Given this list of marker genes Usp25, Spata13, Jmjd1c, Gpd2, L3mbtl3, Crim1, Cbx5, Aasdhppt, Cyfip1, Gk (NCBI Gene Id 319419), Pank3, Atp7a, Angpt2, Mllt3, Lmbrd2, Pcsk5, Ube2d3, Zfp626, Zfp81, Elapor2 (endosome-lysosome associated apoptosis and autophagy regulator family member 2), Xcr1, C330018D20Rik, Gucy2f, Smarcd1, Washc5, Aqp4, Sh3gl3, Morf4l1, Cse1l, Ak2, Lypla1, Slc41a1, 1700129C05Rik, Pigo, Crmp1, Ski, Srgap1, Pcdhb16, Olr1, Ipmk, Nr2f2, Mmp13, Arl14epl, Il7, Prex2, B230219D22Rik, Ift70a1, Peli1, Lmo2, Spopl, Ino80, Slc25a30, Gypa, Desi2, Gadd45a (NCBI Gene Id 13197), Mbnl2, Cts7, Rbm20, Agtr1b, Ffar4, Zfp746, Sun1, Prpf4b, Trmt2b, Fam118b, Tmem263, Dclk2, Lnx2, Mtx3, Hsp90b1, Crybg3, Sdk1, Frat1, Pakap, Acp3, Rictor, Kctd4, Bicd1, Pcdh10, Nr2c2, Ccdc89, Arhgef28, Ankrd17, Klhl7, Eloc, Cenpc1, Ptpra, Scp2, Nap1l4, Rad51, Phlpp1, D5Ertd579e, Nmur2, Atad2, Phip, Zfp91, Rev3l, Gabra2, Dnajc27, Frem2, Rora, Eea1, Cpne8, Cpn2, Cep72, St8sia3, Ddias, Lats2 (NCBI Gene Id 50523), Abcb1a, Tm9sf3, Dbnl, Ifi213, Far1, Slc8a1, Camsap3, Zdhhc17, Doc2a, here is a description of the gene set: species: Mus musculus Genes predicted to be targets of miRBase v22 microRNA mmu_miR_101a_5p in miRDB v6.0 with MirTarget v4 prediction scores > 80 (high confidence targets). from publication Chen Y, Wang X (PMID 31504780) Mouse Gene Set: MIR_101A_5P